Given this list of marker genes Syk, Clec4d, Rabgef1, Nfkb2, Klrc1, Mmp28, Sh3bp2, Tnfaip8l2 (tumor necrosis factor, alpha-induced protein 8-like 2), Gnai2, S100a7a, Map4k1, Gpr108, Gfi1, Lgals3, Pbk, Fos, Stk17b, Sit1, Gpr34, Bcap31, Plau, Trim27, Sstr4, Arrb2, Timd2, Tnip1 (NCBI Gene Id 57783), Smcr8, Slc5a2, Nlrc3, Prdx5, Gstcd, Timp3, Dmd, Cd300a, Dusp10 (NCBI Gene Id 98270), Ido1, Cd274, Ccr4, Lpar2, Usp13, Cblb, Nfil3, Aire, Bpifa1, Inpp5d, C1qtnf4, Trafd1, Ptpn2, Wdr41, Mir425, Nucb2, Stk38, Unc93b1, Timd4, Sod3, Il17b, Prf1, Pycard, Ccr1, Adora2b, Dusp4, Hif1a, Adcy7 (NCBI Gene Id 11513), Ash1l, Aim2, Clec4n, Stat3, Trim8, Uaca, Tank, Cd200r1 (NCBI Gene Id 57781), Il19, Pik3cg, Grn, Irak3, Tax1bp1, Mertk, Adrb2, Ncoa3, Pomc, Stx11, Dusp1, Ebf1, Mgat5, Tbk1, Map3k7, N4bp1, B3gnt6, B3gnt2, Fyn, Dpp3, Treml1, Ccr2, B2m, Arhgap17, Ddx46, Hsf1, Tnf, Ifngr1, Ifnb1, Sod1, Mir146, Trpv1, Tnfrsf10b, Rnf20, Zc3h12a, Mir122, Clec12a, Muc2, Slc37a2, Rc3h2, Lgals3bp, Nckap1l, Cd44, Ptgs2, Serpinb1a, Tbx21, Nlrp1a, Socs2, here is a description of the gene set: from publication Motenko H, Neuhauser SB, O'Keefe M, Richardson JE (PMID 26092688) Mouse Gene Set: MP_INCREASED_TUMOR_NECROSIS_FACTOR_SECRETION Mouse genes annotated to increased tumor necrosis factor secretion (MP:0008560) retrieved from the Mouse Genome Informatics database via MouseMine species: Mus musculus